The following is a description of a gene set: species: Mus musculus Mouse Gene Set: TABULA_MURIS_SENIS_TONGUE_LANGERHANS_CELL_AGEING from publication Tabula Muris Consortium (PMID 32669714), and this is the list of marker genes: Ptprcap, Sema7a, Thy1, Lat, AW112010, Nkg7, Atp5mj, Skap1, Odc1, Ctla2a, Cfp, Mfge8, Cxcr6, Psmb8, Icos, Ifrd1, Ly6g5b, Cd83, Rpl38, Cd3g